The following is a description of a gene set: species: Homo sapiens Genes containing one or more binding sites for (ZNF407) in their promoter regions (TSS -1000,+100 bp) as identified by GTRD version 20.06 ChIP-seq harmonization. from publication Yevshin I, Sharipov R, Kolmykov S, Kondrakhin Y, Kolpakov F (PMID 30445619) Human Gene Set: ZNF407_TARGET_GENES, and this is the list of marker genes: ILF3, MFF, TMCC3, SHLD3, EIF6, C2orf42 (chromosome 2 open reading frame 42), RADX, C19orf47, DENND6A, ZNF514, PACSIN2, ZNF512, FANK1, VTRNA1-1, ANO10, ARMC6, TAF6L, RN7SL346P, ZNF292, BSDC1, MYO6, CWF19L2, NFKBIZ, ATP8A1-DT, REPIN1, H4C8, CHMP6, RWDD2B, SRSF10, NECAB2, TMED2, KLHL12, TRIM33, SNX1, MTREX, CENPU, TAL1, RNF126 (ring finger protein 126), PCGF3, CDK5RAP2, DNAJC16, PPM1L-DT, ZNF609, PLBD2, DDX42, DTL, KCTD3, SLC35A3, BDNF-AS, CTDSPL2-DT (NCBI Gene Id 120017340), FBXO16, ARHGAP6, ARFGEF2, ZNF511-PRAP1, RAB3A, ARHGEF26, MSL3-DT, ATG4B, DUSP12, PSMD14, ZNF84-DT, NIFK-AS1, UTP14A, TMCO1-AS1, GPI, CREBL2, PMEL, HSD11B1L, HOXC13, HEXA-AS1, HIPK1-AS1, ARF6, POLG-DT, FPGT, EMC2, TBCB, FAHD1, B4GAT1, NUTM1, RAD50 (RAD50 double strand break repair protein), VIRMA-DT, USP32, SGO1, PLK4, STX4, IFRD2, UBAC2, COX6A1, DCUN1D3, WDR62, TMEM106B (NCBI Gene Id 54664), OGFOD2, KHDRBS1, ZFAND1, EEF2 (NCBI Gene Id 408221), TTC31, FAM78B, LGALS8, MTHFR (methylenetetrahydrofolate reductase), ARHGAP11A, PSMC3IP, ALDOA (NCBI Gene Id 226), ZC4H2, PRKACA, LINC00687 (long intergenic non-protein coding RNA 687), PYROXD1, FPGT-TNNI3K, EIF4ENIF1, OSTM1, ADAT2, MCOLN1, RPUSD4, CHST10, GTF2B, BARD1, LIG4, RAD1, LSM6, PPP6C, LAD1, RHBDD1, UTP18, DNAJC19, MPG, CEP43, PBK (NCBI Gene Id 55886), MIR4706, LUC7L, DBF4B, ATP6V1F (NCBI Gene Id 9296), HSD3B7, ALG1, BABAM1, ATPSCKMT, WDR75, CDCA3, PRKCI, ASAH2B, PADI1, TCHP, NDUFA9, PIP5K1A, RPL3, C17orf58, TSPOAP1-AS1, IER2, RPGRIP1L, UBAP2L, CABIN1 (NCBI Gene Id 26293), C20orf96, STK33, OGA, BAGE2, RPRD2, SLX4IP (SLX4 interacting protein), NAGA, NDUFS1, FASTKD5, RBM33-DT, SEPSECS, MACC1, DIDO1, NDUFA7, SCFD2, YIF1B, CLEC2B, TMEM79, MIRLET7IHG, RN7SL693P, TREHP1, SMC2-DT, UBE2N, NIPAL1, VPS39, SUGT1, LANCL1, SAMD8, DARS2, DMXL1, ATP6V1C1, PSPH, FOXA3, CSDE1, AOC4P, UBE2G2 (NCBI Gene Id 7327), METTL1, AGBL5-AS1, ZNHIT1, DUSP1, CD164, NSMCE2, KLRG1 (NCBI Gene Id 10219), VTA1, TBCD, EIPR1, FRA10AC1, PLEKHG3, CRIPT, PTBP1, CES2, TEKTIP1, HAUS4, UFSP1, RAB5A, RELB, SYNGR3, ACOXL, RNF113A, C5orf52, PCM1, ENPP3, ZDHHC6, RNF5, CEP295, NAA38, APOOL, RPA2, GDAP2, FUBP3, JMJD8, ZBED6, HCG14, FMC1, FUT1, BRPF1, OBI1, NAMPT, E2F6, FAM161A, LAMTOR5-AS1, ATP1A1-AS1, TNFAIP8L1, SEPTIN7P2, EIF2B5, AGBL5, GLA, SBNO1, GOLGB1, MYDGF, DMXL1-DT, LIN52, BSG, TXNDC17, NAA30, RCE1, PIGB, EGFL7, TRAPPC9, MCRIP2, SYT7, ALG9 (ALG9 alpha-1,2-mannosyltransferase), TMEM258, ERC1, DDX28, ADO, SETDB1, PIAS2 (protein inhibitor of activated STAT 2), PCMTD2, GABPA, BCL6, MRPS31, CCDC74A, ZNF584-DT, CHIC1, CNOT9, BUD13, DNAAF10, DIPK2A, CXorf58 (NCBI Gene Id 254158), ABCA7, WDR5, NEIL2, C17orf75, WWOX, MST1, SGO1-AS1, DAXX, ZC3H12D, BNIP1, VTI1A, ISOC1, TDG, RNU5E-4P, RNU4-86P, ARPC1B, RAI14, RABL6, CHMP3, AP5M1, CISD1, BAX, PEX19, SLC9A5, RAD51D, MIR548XHG, FBXO22, LINC00649, RPL7L1, CAPS2, ZBED4 (NCBI Gene Id 9889), LZTS2, MTIF3, VANGL1, ZNF350, RPL26L1, BMF, H4C5 (NCBI Gene Id 8367), BSG-AS1, DRC3, EMX1, RANGAP1, PIAS4, ENSG00000268129, FAM111A, CENPS-CORT, TARS1-DT, SMN2, FN3KRP, ARFGEF1-DT, ZNF891, LANCL2, AARSD1, TERF2, BZW2, ZBTB8OS, VPS26A, ARV1, MED28 (NCBI Gene Id 80306), STK17B, OPA1, LINC02026, PISD, ZGRF1 (zinc finger GRF-type containing 1), SMIM29, SLC35F6, ICAM2, VTRNA1-3, IPO9, ARMCX6, NAPA-AS1, ATR, KIF16B, CHURC1, NOL6, SERP1, PEX11B, CFAP65, ARFGEF1, FOXM1, ATG9A, ENSG00000261118, RPAP1 (NCBI Gene Id 26015), EXO1, STC2, SON, SDCCAG8, TRPC4AP, LHX1, TMED10, TRAPPC2L, CENPE, ARMC1, MYO15B, NLK, LRRC37A3, RAB27A, ELF1, INPP5K, GLMP, ENSG00000272008, FRRS1, LRCH4, ACD, NR1D1, SIAE, MVB12A, ATP6V0B (NCBI Gene Id 533), KCNN3, TRIQK, SEC23IP, PWWP2A, SMG1P3, VPS33A, CCDC24, RAB5C, ABHD13, CARF, NRXN3, PUS1, RHOT1, KIAA0753, SLC7A5P2, KIF22, POLG, SDAD1, TSPOAP1, TRAPPC13, HIPK1, AGTRAP, EFNA3, URI1, RBL2, SNX5, MSRA-DT, PSMC1, BORCS7-ASMT, PHF23, CRYZL1, BORCS7 (NCBI Gene Id 119032, BLOC-1 related complex subunit 7), NUP188, WDR3, ORAI1, TMED7, PSRC1, SUGT1P4, GIGYF2, SLMAP, AP4B1, UNC50, NBAS, PICALM, MAG, CDC123, OAZ2, LATS2, CTDSPL2, AEBP2, MIR4530, TRUB2, DERL2, TGOLN2, CERS4, MCM8, SLC16A5, CDIPTOSP, RN7SL736P, SH2D6 (SH2 domain containing 6), GFI1B, SMAD2, SPOCD1, SLC2A1, H6PD, THADA, RBIS (ribosomal biogenesis factor), DPP3-DT, CLPTM1, SHOC2, UPF2, NACAD, SRRM1, RPS24, PABIR2, SQSTM1 (NCBI Gene Id 94002), CHAF1A, TRPM4, METTL2B, POLR3E, FCMR, SNORD43, PIPOX, FADS2, ERP29, RPS6KA1, FRG1JP, TTL, NXT2, HSPG2, ZNF613, KIF9, ZNF691-DT, POLR1D, U2SURP, TNPO2, MBTPS1, CHD9NB, HAPSTR1, FOXN3, MKKS, ZNF672, KDM6B, RUSF1, XPNPEP1, TMED7-TICAM2, PPP1R2, TMEM128, HNRNPF, EPC1-AS2, PRMT7, ZNF865, EPCIP-AS1, LRRIQ1, NTMT1, RPL7L1P8, GTF2IP20, ASAH1-AS1, C9orf43, ZNF581, DDX54, PPP1R35, PLXDC1, EHD1, PTMA, CTDSP1, RFX3-DT, ARL5A, RPL26, PLOD3, CENPA, LENG8, BLOC1S6, DUSP18, ABHD16A, FOLR1, USP54, SYNCRIP, TIAL1, KIF13B, WASHC2A, LARP7, KLHL7, PHF20L1, ZNF84, EP400, MIR7976, NUDCD3, IREB2, HMG20A, TADA1, EPG5, CDK12, ZNF793, KLHL8, PIERCE1, BCR, POLR2D, MMADHC, EIF2B4, FZD9, CCDC107, FAM83C-AS1 (FAM83C antisense RNA 1), TSNARE1, RNF121, RAB3GAP2, IFNAR1, AAR2, STAU2, RPL38, SUGT1P4-STRA6LP-CCDC180, PABPN1, GKAP1, ZNF721, GORAB-AS1, ACTN2, WDR41 (WD repeat domain 41), NEMF, ZNF75D, SMAP1 (small ArfGAP 1), UBE2Q2P1, FAM228B, AFF4-DT, RNF146, ZNF879, MAP2K4P1 (NCBI Gene Id 139201), SRR, IFT74, KANSL3, SUGT1-DT, MSH3, LAMTOR2, TRIM7-AS2, PTCD2, BCCIP, PPP1R15A, RPL32, SSBL4P, SEPTIN7P13, SACM1L, LNPK, ORC4 (NCBI Gene Id 5000), COX6C, PLEKHJ1, PLCD1, NIF3L1, EARS2, H2AC25, GTPBP6, GOLGA8B (NCBI Gene Id 440270), ZBTB9, RCHY1, HSDL2-AS1, POLR1C, SLCO2B1, MAPK8IP3, NEMP2-DT, MIA3, KDF1, NUP50, WDR11, HRC, ENSG00000187951, ZNF747-DT, MCCC1, NAT10, MGME1, KCNAB1, PRSS22, ILF2, HYAL2, CCDC159 (coiled-coil domain containing 159), CRAMP1, ERCC5, RFX3, CLASP1, NPHP1, BRIX1, EPIC1, YY1, SATB2, COX11, USP1, TTC32-DT, DLAT, UTS2B, XRRA1, CNPPD1, SNX17, VGF, VPS29, ENSG00000267698, DCAF12, BTN2A2, DMXL2, ZNF823, MYH9, COMMD1, KLK1, CHMP7, MIR5091, RAB3D, WDR43, TMBIM1 (NCBI Gene Id 64114), ARPC1A, G6PC3, ASXL1, ADAMTS6, POC5, RANBP9, TMEM259, CEP162, FBXO33, ATAD3B, RAD51C, FRG1DP, PPP2CA (NCBI Gene Id 5515), MBLAC2, SNHG33, NCEH1, ETV7-AS1, UBOX5, RPL26L1-AS1, COA6, GAR1, SIRT1, USPL1, EIF4B, HOXB7, KCNJ11, CENPT, SMARCAD1-DT, TOMM5, NSRP1, WASHC2C, USP34, RNASE11, ANKRD13A, HOOK2, LINC02427, SRRT, TMEM184B, CGGBP1, RNASEH2B-AS1, CLN3, ADRA1A, TYW3, EEF1A1P23, SREBF2-AS1, LHX4, MBTD1, BMS1P4, MED29, DHX33, VOPP1, RBM43, CDKN1B, SLC30A6-DT, UQCRQ, LINC01424, UBQLN4 (NCBI Gene Id 56893), KRT7, ZNF207, LAMP1 (lysosomal associated membrane protein 1), ZNF575, C1orf220, COA6-AS1, VPS33B-DT, COIL, TMCO1, WASF2, CLPP, MVK, LARS1, AGPAT1, H2BC26, NUDT5, GNPAT (NCBI Gene Id 8443), DBT, FBXW11, BYSL, CWF19L1, CFAP46, ARL5AP5, TRIM36, MRPL17, TADA3, UBALD2, PPP1R10 (NCBI Gene Id 5514), MRPL30, FRG1HP, TMEM254-AS1, FAHD2A, LINC01341, SMARCD2, USE1, MAPK3, HCG27, CUL2, USP42, MYCBP2, LINC02572, KPTN, SGMS1-AS1, USP9X, SPNS1, CDKAL1, XNDC1N, DVL2, SPDL1, GPR3, MRPL46, ELP6, DNAH2, RBBP4, CRYZ, ZNF333, PRKCSH (PRKCSH beta subunit of glucosidase II), ATRN, SREBF2, ZNF649, PPP1R15B, RBPJ, NPRL3, NCOA7, MCL1, POLR2I, NAALADL2, GORASP2, HDDC2, SRRM5, TUBGCP2, ARL5AP1, CHCHD5, KIF27, VPS33B, SPAG7, SAMM50, SYMPK, RSRC2, PCBP2, TARS1, USP28, ATF6-DT, SELENOW, LINC00229, ZFTA, ZCCHC7, ZC3H11A, H4C1, LRP3, EIF3B, LPCAT4, STX8, COPS4, ZNF175, ALKBH6, COQ5, PLEKHB2 (pleckstrin homology domain containing B2), DNAJC27, TOM1L2, LEFTY2, CHCT1, NKAIN1, DDOST, SLC4A2, TMEM87A, ZNF638, PTPRF (protein tyrosine phosphatase receptor type F), USP37, FITM2, PSME3IP1, RNF123, CHMP4A, WBP2NL, TTC32, LRRC14, KIAA0513, CEP170, C19orf38 (NCBI Gene Id 255809), CALR (NCBI Gene Id 811), CHEK1, MYO1C, STK35, GPN3, AGGF1, HGS, CFAP418, DDX41, IL13RA1, SLC39A6, CENPL, PTPRE, MZF1-AS1, NCSTN, NAPG, ODF2L, ZNF324, S100A2, ENSG00000260288, SNHG17, MAP3K4, ICA1L, ETV1, YJU2, ANKIB1, MBD6, BRD7, TOE1, SMIM31, AFF4, PLK5, ZNF320, ABALON, TSFM (Ts translation elongation factor, mitochondrial), RSBN1, ENTPD6, ACAD10, ODAD3, POLD3 (NCBI Gene Id 10714), BBS5, FEM1B, DENND6A-DT, ZNF277, MTFR2, MLLT1, PPT1, C12orf57, CEP95, EFTUD2, TNIP1, ZNF747, RBM15-AS1, LINC02583, KIFC1, TSACC, FMNL2, ARHGEF12, NDUFB5, COPS6, LINC01623, ZDHHC21, PIP4P1, WDR36, EXOC7, SUGP2, TMC5, GATAD2B, PGBD2, MYNN, MMAA, SCYL2, DCLRE1A, PICK1, ARFGAP2, FAM47E, PSMA1, MRPL35, CCT3, RETREG2, TSPAN19, ZMYND12, PPEF1, MRPL22, PSMG1, B4GAT1-DT (B4GAT1 divergent transcript), LRRC27, STXBP4, PPP2CA-DT, FRG1, CTSB, NME5, CDIPT, MRPS35 (NCBI Gene Id 60488), COASY, BMERB1, LENG8-AS1, NUP155, SLC38A6, DDX3X, CENPS, COPS7A, ZNF184, IL5RA, LONP2, FNTB, C9orf72, TMEM242, ARL6IP6, VIRMA (NCBI Gene Id 25962), LINC00898, SUCO, CNTRL, PLCH1, TCP11L1, IRAK1BP1, CTCFL, DPP3, RAMACL, RETSAT, BAG6, HMGB3, PPM1L, RPL36, CHURC1-FNTB, RNASEK-C17orf49, EPC1-AS1, FDX2, GSTM4, NUF2, COQ4, TMEM248, MCTS1, CNTNAP2, RNASEK, MTMR10, NDUFC1, POLR2L, LAMTOR5, KMT2A, SNX2, PPME1, CCDC103, GIPC2, TMEM104 (NCBI Gene Id 54868), MSL3, METTL26, MIR6815, DOHH, TSEN2, KCNIP2-AS1, FAM168A, RALY, TTC23L, LRRC46, ESS2, PGLS-DT, GRPEL1, SERF2, TXNRD1, CCNT1, EXOSC3, LINC01960, WDR12, RPL34, DCTN4, EIF2A, PPP2R3C, TBCEL, EIF1B-AS1, SYVN1, DEPDC1, NOP10, KIF3C, CDK5RAP3, UQCRC2, GID8, PIP4K2C (phosphatidylinositol-5-phosphate 4-kinase type 2 gamma), PLD3, SYNGAP1-AS1, DIS3L2, PRKRA, BROX, TRAPPC4, MRPL19, VPS37C, C1orf174, ERI2, DYNC1I2, FRG1GP, ATAD3A, VPS26C, NTHL1, RACGAP1, MAP1LC3B, SGMS1, NAMPT-AS1, ARL3, TRAF5, SASS6, SEC23A, SNHG31, AMOT, POLR3G, NAA16, QSOX1, MROH8, RNASE4, MRPL47, GTF2H1 (NCBI Gene Id 2965), TRAF3IP2, ULK4, TMEM30A-DT, ARHGAP11B-DT, ARID1B, SNRPB2, MSL2, MORF4L2, STRN3, NELFA, C1orf53, CECR7, ZNF789, CCAR1 (NCBI Gene Id 55749), GET4, STK32C, IKZF5, PAF1 (NCBI Gene Id 54623), RPS26, CAPG, CROCCP2, ESF1 (ESF1 nucleolar pre-rRNA processing protein homolog), THAP2, TP53BP2, SLC7A6OS, SERPINC1, AP1S1, RPE, SUPV3L1, ATG3, FAM53C, STMN1, POGLUT3 (protein O-glucosyltransferase 3), SEC23A-AS1, CYRIB (NCBI Gene Id 51571), AP4E1, BCL2L13, CDS2, ELK4, LTO1, SELENOK, AAAS, ALG14, FKBPL, TINAG, TJP1, TAF11, SKA2, NAT9, GOLGA8A, RO60, APOBEC3G, RPGR, IFT70B (NCBI Gene Id 150737), SLC35A5, SLC30A6, RFC3, MST1P2, CGRRF1, GANC, HPS5, CAPN10-DT, RPL34-DT, AP5S1 (adaptor related protein complex 5 subunit sigma 1), HOXA11-AS, MAP3K14, RPTOR, IGFLR1 (NCBI Gene Id 79713), TAB3, CLUAP1, OSGEP (O-sialoglycoprotein endopeptidase), EEF1B2, TMEM129, ZNF460, ZNF654, PA2G4, KRBA1, ZFYVE27, FMC1-LUC7L2, CDC14A, HEXA, PGAM5, ZFAND2B, DCLRE1B (DNA cross-link repair 1B), KMT5A, ASB3, GNRHR2, SMIM27, C1orf131, B9D1, MFAP3L, SMG6, DMTN, FAM21EP, HNRNPH2, SUB1 (SUB1 regulator of transcription), FIZ1, EIF3M, IKZF2, RAB21, LINC01970, FAS, PDCL (phosducin like), ANKRD34A, DANT2, SWT1, MED12, CDC42SE1 (CDC42 small effector 1), TRAPPC8, MIR4521, ATP8B1-AS1, PGLS, ADGRG1, BIN1, NDUFS4, CPEB4 (NCBI Gene Id 80315), ZNF76, MMAB, AKAP11, SF3A2, DOLK, MED11, PLAA, HACL1, COPA, BMS1P4-AGAP5, HAGH, ITGA7, ITSN1, PPP1R7, GORAB, UBFD1, MRPS18B, BTD, TRMT6, TTC7A, GLI1, ZNF668, ABHD11, CCN1, RAD51, GABPB1, CCDC142, PDE8A, SS18, PSMD10, LCMT2, RSPRY1, RASA1, SECISBP2L, MDH1B, ZNF322, DDX12P, TMEM62, NUP42 (nucleoporin 42), ATP13A4, UFL1, PAXIP1-AS2, NEMP2, SPA17, PLCG1, COX5A, KLHDC1, GLCE, EPHA3, TRMT5, MCMBP, GDF11, HNRNPA3, SEPTIN11, TMEM250, KLHL28 (NCBI Gene Id 54813), FAM168B, DUS3L (dihydrouridine synthase 3 like), KLHL18, UQCC6, PEX3, ARPC4, CCT6A, ITGA2, ZNF599, FASTKD2, FAM47E-STBD1, ISLR2, RCOR2, ELP2, PBLD, RAP2A, PFKFB3-AS1, DHFR, KNTC1, PEAK1, TXLNG, FAM187A, PDE7A, LAMTOR1, PRR13P5, ZEB1, BOD1L1, HNRNPD, USP39, GTF3C2, WWP1, ENSG00000214708, DYNLRB2-AS1 (NCBI Gene Id 102724084), STX1B, GOLGA4, LINC02405, STRN, UBXN1, CUEDC2, DNAJA4, PRPF3, SHC1, SCNM1, ELOCP29, COA5, MTMR4, PDXDC2P-NPIPB14P, ATPAF2, NDUFAF5, ZNF684, EIF2B5-DT, SLC36A1, MIR4258, RTCB, CD70, DDHD1, UBE2Q1, TEX14, MCRS1, SCYL3, ING5, SYT12, GTF2F2, MRPS35-DT, COPB1, TMBIM6, CUL9, LINC01002, NFATC4, CFAP52, POLE3, MINPP1 (multiple inositol-polyphosphate phosphatase 1), HDGF, ATF1, HSD17B12, SMCR8, PDIK1L, LGALS3BP, FEN1, CLPX, BLOC1S1, TMF1, PDXDC1, INTS7, RPL5, TRMT1L, COX20, EIF4G1, POLR3GL, POLRMT, GPR107, MNT, ST20, APOO, VPS50, ZNF646, ACADSB, RCOR1, WASHC5, TTLL11, DOCK4, B4GALT3, HOXA-AS2, DNAJC27-AS1, RPS12, ANKZF1, MRPL13, COMMD4, ATF4, INO80E (INO80 complex subunit E), PHKB, CNEP1R1, CCDC18, DEGS1, ZC2HC1C, CLUH, EI24, MARK2, SMARCAL1, CHCHD3, ARL16, FRG1BP, IPO9-AS1, SRSF1, CNPY2, CDC20-DT, ZNF793-AS1, SIN3A, LINC02901, ZDHHC7, CSTB, TSGA10, PSMD14-DT, SLC39A8, EXOSC10-AS1, TMEM184C-DT, FBXO24, SIAH1 (siah E3 ubiquitin protein ligase 1), SFXN2, ZNF449, RBM10, ZNF775, COA3, MPV17L2, STX16-NPEPL1, PSMA5, DYRK4, LYSMD1, CHD1, PUS1-AS1, ALDH6A1, NHLRC2, ABCB9, RC3H2, ERLIN1, PDE7A-DT, RNF8, AP2A1, EIF1B, NDUFV2, MCFD2, DGAT1, STX16, MANSC1, FAM21FP, DNAJC1, PFKFB3, POLR3A, CCDC13, UBE2B, FTO, RAB11A, KAT5, SAE1, NACA4P, APEX1, PRPF40A, FRG1-DT, HUS1, DARS1-AS1, LINC00477, COMMD9, MICOS13, ZNF577, SEPSECS-AS1, SLC35E2A, PRAC2, GIRGL, SFXN5, ZNF451, PLEKHG5, CUL5, ZNF518A, SNRPA, RPS6KA5, EXOG, MARCHF8, MFF-DT, MYG1, ATP6V1G1, ST20-MTHFS, PRKAR1A, CYB5B, LINS1, COG7, HMGN4, RAD9B, NECAP1, HEATR1, HSDL2, SUDS3, NAA15, RPS19BP1, ZFYVE26, FAM117A, BBIP1, SLC27A1, SYNGAP1, CDKL1, PSMA4, GINS1, PTTG1IP, ZNF524, MRPS33, PRORP, TNFRSF1A (NCBI Gene Id 8077), DAD1, RHOBTB1, KIAA1958, ACOX3, FRG1EP (NCBI Gene Id 102723390), C2CD2, ALS2, MAN1A1, LINC01976, EME1, CDK20, GCA, DNAJB13, TTC13, SNHG7, UFL1-AS1, FAM216A, ZSWIM1, OS9, G3BP2, TTC14, CMC2, AK2, MXRA8, H2AC21, PPOX, TIMM50, MED20 (NCBI Gene Id 9477), CEP152 (centrosomal protein 152), MSRA, NSUN6, ENSG00000236098, LIPT1, MTRR, ATF2, ODR4, CKS1B, HAX1, KBTBD4, TNFAIP3, NEURL4, UCKL1, GTF2IP13, LINC01703, THYN1, GALE, UBE2H-DT, MRPL27, CIPC, SNAPC2, FAH, PITPNA-AS1, NFX1, ZNHIT6, TMEM242-DT, ELAVL1, RPL24, MBD5, CCDC47, IER3IP1, MAD2L1-DT (NCBI Gene Id 121009649), CCT5, FLAD1, SMC2 (structural maintenance of chromosomes 2), TRMT1, ASB7, TMEM185A, STX10, ULK3, NFKBIE, HEPH, CIAO2A, GDF9, LYRM1 (NCBI Gene Id 57149), NR2F6, UFC1, ASAH1, APIP, ZDHHC1, ARMC5, CIAO2B, TOP3A, MTBP, TMEM254, NR5A2, RAD9A, BAZ1B, DNAJC18, INO80B, NR2C1, TMEM30A, PUM3, DARS1, ATG4C, CNTD1, FNDC3A, QTRT1, ILVBL, ATP5PO, SRFBP1, ATF5, UBE4B, TRIM41, NUDT13, TRNT1, ZNF511, AIDA, ARPC4-TTLL3, BANP, GABPB2, STAM2, MRPS27, PTCH1, MAD2L1, MIS18BP1, KLHL25, EDC3, RNVU1-26, HSP90AB1, SEPTIN9, ACAD8, IL23A (interleukin 23 subunit alpha), INO80C, PDXDC2P, IGF2BP3, BBS1, APOBEC3F, ACTMAP, FASTKD3, DTYMK, ANO1, TSPYL2, SMARCAD1, DCAF13, INTS4, VPS39-DT, ZCCHC24 (zinc finger CCHC-type containing 24), TAF8 (NCBI Gene Id 135763), TIA1, EED, PDGFB, YIPF3, CLCN6, TMEM205, ALKBH2, ZNF473CR, CDK7, FAM135A, MMS19, PNO1, HCG9, RIMOC1, ZNF649-AS1, RNF220, PRR15, TPR, ZFC3H1, MAPKBP1, GALNS, MITD1, SMC3, DHX16, APOBEC3D (NCBI Gene Id 140565), TMEM39B, LIMK2, PPP6R1, DPP9, ELMOD3, SPATA20, PMVK, PHLDB1 (pleckstrin homology like domain family B member 1), SFT2D1, GIT2, MED28-DT, SNX8, STX5-DT, BRD10, FGF14-IT1, RLIM, PI4KB, SPTLC3, PPP6R3, TNFSF9, ENSG00000232995, TIMM13, TMEM168, SMG5, BRIP1, USP34-DT, YBX1, RUSF1-DT, MORC2, MRTFA, INO80B-WBP1, PIGBOS1, TOMM40, THAP4, ANKMY2 (ankyrin repeat and MYND domain containing 2), THAP6, NUP62, CARD8, TTC14-DT, PKIG, PAN2, HIRIP3, CDKL3, PAXBP1, PNISR, MORF4L2-AS1, SUPT16H, FAM118B, CXXC1, LINC01431, SIK3, KPNA6, FGF13, UBE3A, NUTF2, ARL5B, PRCC, ANG, PNPT1, MIGA2, ZW10, FGF14-AS2, GTPBP4, GGCX, RNF5P1, ZNF133, CAPRIN1, SLC38A2-AS1, RAB8A, PKM, LINC01559, ATG4A (NCBI Gene Id 115201), CHERP, TMED1, SLC49A4, TTC23L-AS1, WAC-AS1 (NCBI Gene Id 220906), LINC01234, MRPS11, LSR, NDUFAF1, DHX32 (DEAH-box helicase 32 (putative)), ZNF16, SOX2-OT, LTA4H, HJV, KRR1, TRGV3, PASK, IFT25, SP2, LINC03060, DDX23, RAB5IF, EEF1AKMT3, ZNF839, ZRSR2, CDK4, SRRM2, SPIN2B, GNS (NCBI Gene Id 2799), ZNF699, RAPGEFL1 (NCBI Gene Id 51195), ILF3-DT (NCBI Gene Id 147727), ZC3H18, LINC02739 (NCBI Gene Id 105369317), SEC31A, LTBP4 (latent transforming growth factor beta binding protein 4), DYRK2, WDR5-DT, LURAP1L-AS1, COL16A1, ARID3C, CAPN10, MPV17, SLC25A51, PPCS, CLDN12, GSDMD, INSIG2, MAZ, TOGARAM1, LINC01257, SMNDC1, FLCN, FBXO31, LRRIQ3, DHX29, DUS2, KDSR, INTS2, AKAP3, DEPDC4, STK40, ANKRD17, TMEM231, CCNT2, AKAP8L, ATP5PF, DYNC2H1, RGS5, PRPF40B, GART, DDX5 (NCBI Gene Id 1655), VAC14, CXCL2, DELE1, SMARCC2, EIF4H, COQ10B, UBTD1, FGD6, IL5, USP5, SNORD101, GAR1-DT, PSMD9, RGL2, GET1, CYB5D1, BUD13-DT, PTPRK (NCBI Gene Id 5796), RPL6, CCDC150, MIR933, LIN7C, ADGRE3, HOXB6, YWHAZ, ENO4 (enolase 4), KNOP1, MFSD1, FAM13A (NCBI Gene Id 389211), PARP12, AHCYL1, PDCD2L, MTLN (NCBI Gene Id 205251), STK25, IRGQ, GTF3C6, BLMH, RFK, ILK, ALDH1A2, CDC6, SLC38A2, IFT140, SNRPC, RITA1, TNRC6B, ANAPC13, ARID5A, FLNC-AS1, B4GALT4, ZNF407-AS1, POLR2J, ATP6V1H, PTPN13, PALM, MIS12, VPS35L, CCND3, LNCTAM34A, EBLN3P, STX1A, CPS1, FRG1CP, COMMD10, EXOC5, C2CD3, OCRL, NDUFB8 (NADH:ubiquinone oxidoreductase subunit B8), ENSG00000260592, CMTR2, MESD, WDR83OS, GSPT1, TMEM222, POLB, NPY1R, LYPLAL1-DT, SREK1, HEIH, PAIP2 (NCBI Gene Id 51247), ZNF691, SPCS2, FCHO2, PPRC1, HSPA6, SLC25A32, FMR1-AS1, RPS7, ACOX1, RPL21P122, UBE2M, ZBTB17, PPP4R3B, ERMP1, GID4, ERLEC1, GABPB1-AS1, RNU6-1301P (RNA, U6 small nuclear 1301, pseudogene), HSPBAP1, ENSG00000282936 (novel protein), SNHG15, CHM, ARHGAP29, CCNT2-AS1, WDR83, NME1, PKNOX1, MISFA, CLCN7, OR4N5, LIMD1-AS1, CHCHD4, GSPT2, MGST3, ARF4, KDM4C, KRIT1, RAB5B, RRP8, TRIM23, ARPC5 (NCBI Gene Id 10092), TRMT13, GNB2, ANKHD1, TM9SF2, PJVK, SUGT1P4-STRA6LP, FGGY, AP3B1, TSC1, GTF3C2-AS2, PBXIP1, MAP2K7, DNMBP, RHNO1, SCRIB, METAP1, MRPL10, RGL1, TIMM8A, ARHGAP11A-DT, MRPS2, CFAP69, THAP8, CASP9, RBM15, GEMIN5, KNL1, DHX40, LINC00513, TMEM116, SCAMP1, EBF2, MED18, GBA1LP, PPIL3, STRA6, MIR548AW, SDHAP4 (NCBI Gene Id 220729), MFSD13A, ANO6, TSPAN4, VAMP8, SLC33A1, NDUFS3, ZNF580, ATAD5, GMFB, BRAP, CCDC33, NUP153-AS1, MGAT4B, ZBTB7C, AHDC1 (NCBI Gene Id 27245), ATF6, CDC20, PFKP, PHF12, MYL12A (NCBI Gene Id 10627), ZNF407, EPN1, ZSWIM8, CHSY1, ENSG00000260830, IL4I1, A2MP1, ROCK1, RAD52, PPP4R3B-DT, APH1A, LINC00933, LYPLAL1, DDX60L, RNF114, ELP3, PRR11, GUSB, REXO5, FMR1, ANKRD36, MTPAP, UROS, GPS2, MED23, CALCOCO1 (NCBI Gene Id 57658), MLST8, RPS16, HNRNPD-DT, ZNF576 (NCBI Gene Id 79177), PIGU, DEDD, L3MBTL2, POP7, SEMA6A, TLE3, NME1-NME2, UCHL5, MIS18A, TSC2, RNU6-92P, KAT14, SUPT5H, ERLIN2, NHP2, TPD52L2, RAET1K, MX1, RPS25, PARK7, SOCS5, ZNF302, VWA8-AS1, NUP43 (nucleoporin 43), WDR11-DT, PRPF31, TFPT, TULP3, UEVLD, PHC1, TMEM267, BCAR3, WWP1-AS1, TLCD3B (TLC domain containing 3B), SIRT7, DHPS, DNAAF11, DYNLRB2, CDC25C, METTL2A, GBA1, CA13, ZNF226, CEP63, ANKHD1-EIF4EBP3, ATP8A1, WAC, MAP3K3, EFHB (EF-hand domain family member B), ZNF384, MAPDA, AP4S1, MTX2, MRPS21, GLUD1P3, PSMB5